Given this list of marker genes ATRX, GTF2E2, ACAN, IL13, HLA-G, SDHD, GTF2H5, RNF113A, AARS1 (alanyl-tRNA synthetase 1), IFNGR1, GALNS, TSPYL1, ERCC2, ALOX5, SCGB3A2, ERCC3, CCL11, MPLKIP, PTGER2, MUC7, TBX21, HNMT, TNF, CARS1, TARS1, here is a description of the gene set: Any anomaly of the function of the bronchi. species: Homo sapiens Abnormal bronchus physiology Human Gene Set: HP_ABNORMAL_BRONCHUS_PHYSIOLOGY